The following is a description of a gene set: Human Gene Set: GOBP_ESTABLISHMENT_OR_MAINTENANCE_OF_BIPOLAR_CELL_POLARITY Any cellular process that results in the specification, formation or maintenance of a bipolar intracellular organization or cell growth patterns. species: Homo sapiens, and this is the list of marker genes: OOEP, CDC42, IFT20, MARK2, SYNE4, PARD6G, TTC8, CDX2, PARD6B, CRB1, TCF15, CRB2, CRB3, MYO9A, ILK, SH3BP1, PALS1 (NCBI Gene Id 64398), ERBIN, FAT1, RHOA, CLIC4, WDR1, ANK1, FOXF1, LAMA1, RAP2A, FSCN1, LLGL1, PRKCI, EZR, SCRIB, DLG5, MTCL1, OPHN1, PARD3, LLGL2, WNT5A, PATJ, ARF4, LHX2, DLG4, CAMSAP3, PARD3B, LRRC7 (NCBI Gene Id 57554), DLG2, PRKCZ, PDCD6IP, MSN, WNT11, DLG3, PTK7, VANGL2, FOXJ1, DLG1, NHERF1, PARD6A